The following is a description of a gene set: The process in which an antigen-presenting cell expresses a peptide antigen on its cell surface in association with an MHC class I protein complex. Class I here refers to classical class I molecules. studied in species Homo sapiens Human Gene Set: GOBP_ANTIGEN_PROCESSING_AND_PRESENTATION_OF_PEPTIDE_ANTIGEN_VIA_MHC_CLASS_I, and this is the list of marker genes: HLA-F, HLA-A, HLA-H, ULBP3, ERAP1, IFI30, ABCB9, MR1, ULBP1, PDIA3, TAP1, IKBKB, MPEG1 (macrophage expressed 1), CALR, HFE, ACE, HLA-B, LNPEP, B2M, SAR1B, HLA-E, TAPBP (NCBI Gene Id 6892), FCGR1A, HLA-G (NCBI Gene Id 3135), TAP2, RAET1G, HLA-C, IDE (insulin degrading enzyme), TAPBPL, AZGP1, MFSD6, RAET1E, FCER1G, ERAP2, RAET1L, ULBP2, CLEC4A